Given this list of marker genes NUDT11, NUDT3, NUDT4B, NUDT4, NUDT10, here is a description of the gene set: species: Homo sapiens Human Gene Set: GOMF_ENDOPOLYPHOSPHATASE_ACTIVITY Catalysis of the reaction: polyphosphate + n H2O = (n+1) oligophosphate. The product contains 4 or 5 phosphate residues.